The following is a description of a gene set: studied in species Mus musculus Mouse Gene Set: GOMF_ATPASE_REGULATOR_ACTIVITY Binds to and modulates the activity of an ATP hydrolysis activity., and this is the list of marker genes: Dnajc10, Hscb (NCBI Gene Id 231610), Sil1, Tor1aip2, Bag3 (NCBI Gene Id 29810), Nkrf, Dnajb2, Hyou1, Hspa4l, Hspa4, Ahsa1 (NCBI Gene Id 217737), Atp1b2, Bag4, Bag5, Fnip2, Grpel2, Hsph1, Katnb1, Atp6ap1l, Bag2 (NCBI Gene Id 74827), Ahsa2, Gtf2h4, Dnajc24, Dnajc15, Atp1b1, Dnajb6, Pln, Atp6ap1, Tsc1, Rab3a, Hspbp1, Dnajb1, Dnaja1, Agrn, Pfn1, Atp5if1, Dnajb4, Grpel1, Atp1b3, Rab6a, Tor1aip1, Rab4a, Bag1, Dnaja2, Dnajc19, Atp4b, Fnip1